Given this list of marker genes SNRPN, DPAGT1, VPS13A, SVBP, EIF4A2, RERE, TAOK1, RAI1, MAPK1 (mitogen-activated protein kinase 1), KAT5, PIGF, here is a description of the gene set: studied in species Homo sapiens Habitual striking of one's own head against a surface such as a mattress or wall of a crib. Human Gene Set: HP_HEAD_BANGING Head-banging